Given this list of marker genes PLPP1, IQSEC1, NRAS, RASGRP2, ZNF217, PRKACA, DUSP6, ETV1, TRIM25, MCC, DUSP4, SYNM, IGHM, RNASE6, TBC1D9, ARHGEF2 (NCBI Gene Id 9181), SPI1, AMPH, JCHAIN, CEACAM1, ACP5, SNAP23, ZER1, MC1R, SV2B, CX3CR1, ARHGAP5, SLC7A7, NCF1C, KCNN4, GATM, PLEC, BCKDHB, RAB4B, RHOBTB3, PSPHP1, CYBB, CD86, CCR2, RNF2, ALOX5AP, here is a description of the gene set: Genes up-regulated in ANBL-6 cell line (multiple myeloma, MM) expressing an activated form of NRAS off a plasmid vector compared to those co-cultured with bone marrow stromal cells. species: Homo sapiens from publication Croonquist PA, Linden MA, Zhao F, Van Ness BG (PMID 12791645) Human Gene Set: CROONQUIST_NRAS_VS_STROMAL_STIMULATION_UP ANBL-6, a myeloma cell line, proliferates in response to interleukin 6 (IL-6) stimulation, coculture with bone marrow stromal cells, and when harboring a constitutively active mutant N-ras gene. Eighteen samples, including 4 IL-6-treated, 3 mutant N-ras-transfected, 3 normal stroma-stimulated, 2 multiple myeloma (MM) stroma-stimulated, and 6 untreated controls were profiled using microarrays interrogating genes. Global hierarchical clustering analysis distinguished at least 6 unique expression signatures. Notably, the different stimuli altered distinct functional gene programs. Class comparison analysis (P =.001) revealed genes (54% involved in cell cycle) that distinguished IL-6-stimulated versus nontreated samples. Eighty-seven genes distinguished stroma-stimulated versus IL-6-treated samples (22% encoded for extracellular matrix proteins). A total of genes distinguished N-ras transfectants versus IL-6-treated samples (26% involved in metabolism). A total of genes, 20% of these involved in signaling, distinguished N-ras from stroma-interacting samples. All 3 stimuli shared genes, mostly of metabolic function. Genes that distinguished MM1 from MM4 clinical groups were induced at least by one treatment. Notably, only genes (ETV5, DUSP6, and KIAA0735) are uniquely induced in mutant ras-containing cells. We have demonstrated gene expression patterns in myeloma cells that distinguish an intrinsic genetic transformation event and patterns derived from both soluble factors and cell contacts in the bone marrow microenvironment.